The following is a description of a gene set: species: Homo sapiens Human Gene Set: HP_PROMINENT_OCCIPUT Prominent occiput Increased convexity of the occiput (posterior part of the skull)., and this is the list of marker genes: IFT81, CNOT1, ALX4, MESP2, RIPPLY2, ATP6V1B2, FLNB, IGF2, SOX6, DYRK1A, DPYSL5, GJA8, KCNQ1OT1, ERF, HYMAI, IFT43, PLAGL1, TBC1D24, CNOT3, IFT52 (intraflagellar transport 52), HES7, CTSK, KRAS, GJA5 (NCBI Gene Id 2702), WDR35, CDK13, RELN, CCDC22, MED12, ATP7A, GDF11, WDR19, IFT122, NRAS, TWIST1, KATNB1, GLI3 (GLI family zinc finger 3), KIF7, TBX6, NDE1, TOR1A, DLL3, SMG9, KCNQ1, NFIX, KAT6B, CHUK, MYCN, CDKN1C, PIGA, NOTCH2, MOGS, RNU4ATAC, WASHC5, FLNA, ITCH, LFNG, PIGN, HRAS, VPS35L, TFAP2B